Given this list of marker genes GSK3A (glycogen synthase kinase 3 alpha), MTOR, FHL2, HEY2, AKAP6, CXADR, PAK1, ADPRHL1, MIR199B, NPPA, MIR208A, PDLIM5, MIR19A, MYH10, NEB, SLC8A1, LMNA, MIR23A, CAV3, SORBS2, ISL1, FHOD3 (formin homology 2 domain containing 3), ATG5, NRAP, MEIS1 (NCBI Gene Id 4211), EDN1, SGCD, PDGFRB, PITX2, NEBL, IGF1 (NCBI Gene Id 3479), BVES, MEF2A, YY1, MIR21, INHBA, MIR195, MIR24-1, JAG1, PRKG1, COL14A1, PLEC, TGFBR3, PDCD4, PPARA, BMP10, TTN, BMP4, CCNB1, ALPK3, SRF, MYH6, ALPK2, GATA4, RGS2, G6PD, OBSL1, SPRY1, SGCB, NKX2-5, SMAD4, MIR199A1, TCAP, MYL2, MAML1, NAGLU, TBX18, VEGFA, TBX3, MYO18B, CTCF, PI16, HNRNPU, MYH11, ADRA1A, CSRP3, MIR19B1, CTDP1, TBX5, PROX1, LARGE1, MYLK3, TOMM70, ASB2, NOTCH1, BMPR1A, LRRC10, ACTN2, ZMPSTE24, RGS4, PDGFRA, NKX2-6, ACTC1, SHOX2, FOXP1, CDK1, PRICKLE1, PARP2, here is a description of the gene set: species: Homo sapiens The process whose specific outcome is the progression of a cardiac cell over time, from its formation to the mature state. A cardiac cell is a cell that will form part of the cardiac organ of an individual. Human Gene Set: GOBP_CARDIAC_CELL_DEVELOPMENT